The following is a description of a gene set: Mouse Gene Set: MIR_382_3P from publication Chen Y, Wang X (PMID 31504780) Genes predicted to be targets of miRBase v22 microRNA mmu_miR_382_3p in miRDB v6.0 with MirTarget v4 prediction scores > 80 (high confidence targets). studied in species Mus musculus, and this is the list of marker genes: Rab3c, Creb1, Zfp827, Haus6, Zfp959, Zim1, Pdia5, Ankrd50, Cntnap5b, Hoxd12 (NCBI Gene Id 15432), Gm15080, Kl, Adcyap1, Hephl1, Acvr2a, Edn1, Nyap2, Entpd6, Gm4841, Gpd1l, Mknk2, Reep1, Lmo4, Sall4, Nfyb, Ppm1a, Wwp1, Spire1, Barhl1 (BarH like homeobox 1), Trib1, Schip1, Sox21, Asph, Kif3b, Cnot6l, Adamts6, Nobox (NCBI Gene Id 18291), Cavin2, Ott (NCBI Gene Id 18422), Chic1, P2ry10, Wnk1, Cers6, Tmem196, Klhl29, Atxn7l3b, Ugt3a1, Col28a1, Tent5a, Ubr3, Ap1ar, Il6ra, Sowahc, Tnpo1, Adcy1, Slc25a44 (solute carrier family 25, member 44), Atxn7, Lrrfip2, Ube2n, Proser1 (proline and serine rich 1), Trhr, Cntn1, Prkd1, Kcnd2, Zfp820, Ptgdr, Hook3, Jcad, Zfp980, Paqr9 (progestin and adipoQ receptor family member IX), Crebzf, Cox17, Pip4k2b, Usp22, C1qtnf5, Gm15085, Neu3, Socs6, Snx12, Zfc3h1, Htr2c, Dock7, Nufip2, Plekha3, Vcan, Hus1, Snai2, Gcnt7, Snap25, Limch1, Gm15097, Pals1, Camta1, Lmx1a, Nuak1, Rab39b, Ano4, Them4, Unc5c, Grem2, Neo1, Fgf14, Onecut2, Plcl2, C1ql3, Dars2 (NCBI Gene Id 226539), Naa35, Tfap2b, Kctd3, Skil, Arih1, Nkd1, Tfcp2, Fam184a, Sema3c, Gcc1, Fut4, Trappc3l, Iqschfp, St8sia3, Slbp, Fam131b, Cdh9, Zic3, Baz2a, Blnk, Tmem268, Map4, Six2, Dcun1d4, Retn, Nfib, Ikbkg, Mff, Hmgcll1, Cd163, Zyg11a, Zfp600, Clasp2, Cpeb4, Mtx3, Tox, Zfp974, Dclk1, Edem3, Eif4enif1, Ppt2, Tns1, Thoc2, Azin1, Usp25, Dclk3, Grik2, Eml4, Tmpo, Dcbld1, Resf1, Setx, Bcl2l11, Lpcat2, Tmem38b, Gm15114, Pde5a, Ppp4r4, Sap18, Ythdf3, Zdhhc3, Aff4, Gpr22, Kmt2c, Slfn14, Metap1, Gpc5, Taf1, Gm15093, Eloc, Adamtsl3 (ADAMTS-like 3), Slc25a25, Dido1, Mkrn2os, Klhl5, Herc3, Fzd8, Pabpc4l, Prkar1a, Ubn1, Cxcr4, Arrdc3, Btrc, Slc66a3, Acvr2b, Rc3h1, Spsb4, Hand2, Cyp3a13, Zscan26, Eif4h, St8sia4 (ST8 alpha-N-acetyl-neuraminide alpha-2,8-sialyltransferase 4), Mtf2, Rcan2